Given this list of marker genes Zfp820, Ptx4, Abcg1, Zscan10, Gm16386, Ndufb10, Gm7742, Tff1, Cldn6, Gng13, Abca3, Gm25049, Amdhd2 (amidohydrolase domain containing 2), Zfp948, Axin1, Mir6968, Gm33727, 9330136K24Rik, 1810014P07Rik, Cerox1, Gm10509, Vmn2r93, Mir7214, Mapk13, Sbpl, Gm18271, Gm17382, Vmn2r90, Vmn2r-ps126, Tsr3, Ccdc167, Mir3082, Lemd2, Vmn2r-ps117, Zfp945, Tbc1d22bos, Vmn2r-ps129, Atp6v0e, Scube3, Vmn2r-ps123, Vmn1r225, Atp6v0c, Vmn2r112, Vmn1r237, Gm7818, Tcp11, Vmn1r229, Gfer, Rhot2 (ras homolog family member T2), D330041H03Rik, Gm6712, Pim1, Gm15597, Snora64, Stk38, Vmn2r105, Ppil1, Ppard, Gm7805, Vmn1r-ps149, Gm7052, Tpsb2, Haghl, Vmn2r113 (NCBI Gene Id 434701), Gm5681, Mir99b, E4f1, Ntn3, Gm9514 (NCBI Gene Id 671007), Wfikkn1, Vmn2r98, Gm6540, Tulp1, Clcn7, Vmn2r107, Bnip5, Armc12, Gm9805, Gm5223, Mir7216, Gm46603, Gm23887, Gm5225, Vmn1r228, Vmn2r94, Itpr3, BC002059, Gm7898, Gm7531, Bnip1, Baiap3, Grep1, Fpr2, Gm46610, Slc26a8, Gm16580, Vmn1r233 (vomeronasal 1 receptor 233), Gm9772, Mir125a, Caskin1, Luc7l, Tpsg1, Zfp97, Vmn1r-ps139, Mir6965 (microRNA 6965), Clpsl2 (NCBI Gene Id 328788), Vmn2r-ps134, Mir7677, Dino, Ift140, 2010106G04Rik, Btbd9, Gm15420 (predicted gene 15420), Tbc1d24, Jmjd8, Gm4786, Vmn2r-ps127, Cramp1, Arhgdig, Hmga1, Snhg9, Zfp960, Kifc5b, Meiob, Zfp995, Rab26os, Zfp54, Vmn2r-ps131, BC028777, Vmn2r103, Zfp160, Rpl10a, Stub1, 4930549P19Rik, Vmn2r104, Gm7912, Mmp25, Spsb3, Oaz1-ps, Hcfc1r1, Uqcc2, Gm50015, Mrpl28, Smim29, Casp16, Gm22146, Glp1r, Antkmt, Gm7072, D630044L22Rik, Gm36486, Gm5232 (NCBI Gene Id 636810), C230013L11Rik, Zfp946 (NCBI Gene Id 74149), Dcpp3, 1700097N02Rik, Zfp943, Cmtr1, Flywch1, Dcpp2, Mir7667, Gm16191, Gm41541, Rnf8 (NCBI Gene Id 70689), Syngr3, Tbl3 (transducin (beta)-like 3), Fpr-rs4, Cpne5, Hba-ps4 (hemoglobin alpha, pseudogene 4), Noxo1, Mir3083, Nme4, Vmn1r232 (NCBI Gene Id 171227), Ciao3, Gm41555, Cox7c-ps1, Gm5492, Gm35883, Eci1, Vmn2r116, Gm18269 (NCBI Gene Id 100416810), Pnpla1, Gm5493, Vmn2r96, Zfp229, Vmn1r235, Pdia2, Fahd1 (fumarylacetoacetate hydrolase domain containing 1), Crebrf, Grm4, Gm5966, Wdr90, Gm5224, Nubp2, Zfp13 (NCBI Gene Id 240046), Mir5125, Cacna1h, Gm5836, Fpr-rs5, Vmn1r-ps148, Zfp944, Fkbp5, Bricd5, Nthl1, Zfp942, Trp53cor1, Mir7217, Gm8186, BC004004, Pxt1, Ilrun, Sox8 (NCBI Gene Id 20681), Tsc2, Gm18214, Pkmyt1, Brpf3, Vmn2r101, Vmn2r-ps118, Vmn2r115, 6330415G19Rik, Syngap1, Flywch2, Tff2, Gm33801, Rnf151, Ccdc78, Abca17, Gm41545, Capn15 (calpain 15), Mapk14, Mirlet7e, Dnase1l2, Def6, Vmn1r-ps140, Mdga1, Vmn2r-ps121, Mapk8ip3, Vmn1r230, Mslnl, Vmn2r102, Vmn2r100, Zbtb9, Vmn2r-ps128, Nme3, Zfp53, Mlst8 (NCBI Gene Id 70343), Zfp983, Prss21, Zfp40, Tmem217, Mir5134, Zfp947, Vmn2r106, Vmn2r-ps132, Nherf2, 1700063J08Rik, Thoc6, Uqcc4, Pgap6, Mir6969, Fgd2, Gm26873, Tekt4, Gm29819, Telo2, Snord60, Pkd1, Anks1, Gm18397, Rps10, Vmn2r130, Gm9703, Gm6402, Tedc2 (NCBI Gene Id 72016), Gm7809, Mcrip2, Zfp52, Ccnf, Mettl26, Zfp523, 9630028I04Rik, C130040N14Rik, Vmn1r236, Vmn1r-ps147, Gm35290, Tmprss3, Dnah8, Chtf18, Eme2, Gm33508, Vmn2r117, Cldn9, Gm18270, Tead3, Srsf3, Prss34, Gm7773, Ggnbp1, Gm41562, Zfp758, Prss32, Fpr1, Srrm2, Unkl, Bicdl2, 4930541O19Rik, Gm7740, Gm17814, Phf1, Gm36199, Gm20008, Ccdc154, Tuba-rs1, Has1, Cuta, Pigq, Tmem204, Gm25921, Traf7, Gm8225, Pi16, Gm5165, Spdef, Gm5430, Vmn2r-ps116, Gm22327, Vmn2r-ps133, Neurl1b (neuralized E3 ubiquitin protein ligase 1B), Lnpep, Rhbdl1, Spaca6, Gm18396, Ube2i, 1700030A11Rik, Gm15458, Igfals, Vmn1r-ps150, Vmn2r114, Kremen2, Zfp598, Vmn2r-ps125, Vmn1r-ps143, Vmn2r99, Vmn2r-ps124, Mrps34, Or14c47-ps1, Pacsin1, Cdkn1a, Lhfpl5, Taf11, Ubash3a, Percc1, Gm10503, Vmn1r-ps142, Gm6811, Gm7732, Zfp760, Elob, Tbc1d22b, Bak1, Gm7217, Gm41556, Fbxl16, Snrpc, Slc37a1, Srpk1, Zfp994, Gm18415, Rpl3l, Msrb1, Rpusd1, Vmn2r108, Gm3946, Gm18519, Gm9937, Gm16005, Vmn1r-ps141, Hs3st6, Vmn1r-ps146, Glo1, Decr2, Rgs11, Rab11fip3, Gm20161, Fpr-rs3, Rab26, Gm34455, Gm25092, Ppp2r1a, Prss30 (NCBI Gene Id 69196), Mir6966, Gm5145, Umodl1, Vmn2r97, Gm8373, Kctd5, Gm18416, Prss27, Gm32892, Fpr-rs7, Gm20109, Tff3, Prss22, Vmn1r224, Vmn1r-ps144, Gm50059, Gm23123, Tnfrsf12a, Gm8437, Pdpk1, Gm15318, Snora78, Gm19012, Vmn1r227, Pgp, Gnptg, Prss33, Gm20026, Vmn2r111, Rab44, Gm30531, Riok2, Metrn, Lmf1, Gm9874, Fance, Rps2, Sstr5, Vmn2r-ps115, Paqr4, Vmn1r231, Nhlrc4, Gm10045, Msln, Gm7513, Fpr-rs6, 1700022N22Rik, Dcpp1, Prr35, Gm41561, Vmn2r-ps120, Bltp3a, Gm49777, Gm41506, Zfp677, Prss29, Rpl35a-ps3, Gm10505, Sbp, Gm7483, Gm3547, Gm3320, Vmn2r-ps122, Vmn2r109 (NCBI Gene Id 637764), Vmn1r-ps145, Itpr3os, Vmn2r127, Ergic1, Tmem217b, Wdr24, E230001N04Rik, Kctd20, Fam234a, Gm5092, Gm7535, Lix1, Prss28, Vmn2r92, Gng5c, Fpr3, Gm26885, Nudt3, Ip6k3, Vmn2r-ps114, Gm50058, Jpt2, Mtch1, Prss41, Gm28043, Zfp51, Gm6705, 1700080C20Rik (NCBI Gene Id 78632), Zfand3, Rab40c, Vmn2r91, Vmn2r110, Npw, Rpsa-ps6, Rsph1, Mir7218, Zfp213, Hagh, Vmn2r124 (NCBI Gene Id 637021), Tpsab1, Vmn1r226, Gm7477, Clps, Rnps1 (RNA binding protein with serine rich domain 1), Dusp1, Vmn1r234, 4930526A20Rik, 9530082P21Rik, Nkx2-5, Mir3547, Rps2-ps9, Gm7736, Vmn2r95, here is a description of the gene set: Mouse Gene Set: chr17A3 species: Mus musculus